Given this list of marker genes GLYAT, SH3PXD2A, DHH, GANC, ATG13, PUS1, CYP2U1, C11orf58, MED13, MLLT3, PTPRR, OR51E2, DCTN1, SNX27, LSAMP, CHD9, TXLNG, ADIPOR1, ABHD15, JOSD1, MEF2C, B3GNT7, DUS1L, NR2F6, POLQ, DSTN, IRAK2 (NCBI Gene Id 3656), FGF14, RAB5B, ZCCHC8, ALX4, LRRC51 (leucine rich repeat containing 51), HDLBP, MPZL1, MDM4, AHCYL2, TCN1, MBOAT2, WDR31, SLC25A39, YAE1, RLIM, DHRS3, CDK6, EIF2B1, DCANP1, SEMA5A, HIC2, PLCXD1, ZNF737, FXN, TPD52L2, FAM83B, MPV17L2, TNFRSF1B, AGPAT4, KLF7, ARID3B, PHF20L1, NUFIP2, FAS, NUP210, IGSF1, SFRP5, TRIM33, XPNPEP3, IRS2, SETDB2, ID4, DRP2, MARCHF9, PRR23C, PAX5, FMNL3, AFF3, HNRNPU, PANX2, PAK3 (p21 (RAC1) activated kinase 3), TFDP2, PPARA, IL17RD, CDH18, EFCAB5, CREB3L1, MAU2, ENOSF1, FGF11, EFHC1, SESN3, IRX4, SCUBE3, CEP164, C14orf93, SLC30A2, UBE3B, TMEM33, VASH2, RAB6B, FCER2, PKDCC, IL9R, PXK, TET3, PITPNB, NTRK1, ATP6V1A, PDSS2, RAP2C, GNPTAB, SLC36A3 (solute carrier family 36 member 3), LRRC28, CADM3, CACNA1E, ZNF587, IRS1, COL19A1 (collagen type XIX alpha 1 chain), GOLGA7, HTRA3, KCNB1, MEIS2, USP3, TOP2A, COL5A1, PTGR3, SPATA31F3, PRMT1 (NCBI Gene Id 3276), NSD2, LHFPL4, FXYD6, FOXP4, ZNF609, IGF2BP2, SPN, LUZP1, PTPN3, DDHD2, ZNF585B, ST3GAL1, PEAK1 (NCBI Gene Id 79834), KCNK6, ZBTB20, PTPN18, G6PC1, WNK3 (NCBI Gene Id 65267), KIAA0753, RPL34, CNIH2, ATPAF1, HAPSTR2, HTRA4, RBM14, UBL3, CBFA2T2, NAA60, MIDEAS, IGDCC3, ANGPTL2, H2AJ, SEMA4F, DESI1, PDE7B, KCNK5, ARPIN, SHFL, RBM4, ZCCHC2, GJB7, SLC10A7, NAA80, ONECUT2, STAT3, GPI, CDC42BPB, ZNF586, CCDC15, EPHA6, SOD2, KCNJ2, NIPSNAP3B, CALM1, SFXN5, DCAF11, RPS6KA1, CLIC5, USP37, THRA, CLCN3, DAGLA, PPP1R15B, TRDMT1, ATAD2B (ATPase family AAA domain containing 2B), CHRM1, here is a description of the gene set: from publication Chen Y, Wang X (PMID 31504780) Human Gene Set: MIR7160_5P studied in species Homo sapiens Genes predicted to be targets of miRBase v22 microRNA hsa-miR-7160-5p in miRDB v6.0 with MirTarget v4 prediction scores > 80 (high confidence targets).